Given this list of marker genes RPS19, RPL28, RPL4, RPL22, RPL7L1, RPS16, RPL39P5, RPS17, RPL18, RNF25, RNF10, HBS1L, RPL3L, RPL38, LARP4, RPS26, RPL37, RPSA2, ASCC3 (NCBI Gene Id 63921), RPL15, RPS2, RPS13, UBA52, RPLP2, RPL27, ABCE1, RPL31, RPS10P5, RPL7A, ZCCHC17, RPS11, ETF1, GCN1, RPS18, RPS23, ZNF598, EIF2AK4, RPL26L1, RPS8, EEF1A1 (eukaryotic translation elongation factor 1 alpha 1), RPL27A, RPL39, RNF14, RPL36, RPL13, RPL5, USP10, RPL35A, RPLP0P6, RPS27 (ribosomal protein S27), RPL19, RPL23, RPS6, RPL37A, RPL39L, RPS27L, RPS4X, RPS4Y2, RPL36A, RPS15A, RPLP1, RACK1, RPL3, RPL29, RPSA, EIF2A, RPL6, RPL18A, RPL11, NEMF, RPS27A, RPS25, LTN1, RPS9, RPL24, RPL10L, RPL26, RPLP0, DDX3X, GSPT1, RPS14, RPS21, RPS12, RPL30, RPS15, METAP1, RPS29, RPL9, RPL35, RPL7, RPS7, RPS24, ASCC2, RPS3A, RPL37AP8, FAU, PELO, RPL10, RPS4Y1, RPL34, TIFAB, DHX29, RPS10, RPL41, RPL21, RPL10A, RPS20, RPL36AL, APOD, RPS3, RPL13A, RPL17 (ribosomal protein L17), RPL23A, RPL8, RPL14, RPL32, RPS5, RPS28, RPL12, here is a description of the gene set: studied in species Homo sapiens Human Gene Set: GOCC_CYTOSOLIC_RIBOSOME A ribosome located in the cytosol.